Given this list of marker genes Slc19a2, Slc25a19, Slc19a3 (NCBI Gene Id 98426), Tpk1, Thtpa, here is a description of the gene set: Mouse Gene Set: REACTOME_VITAMIN_B1_THIAMIN_METABOLISM Vitamin B1 (thiamin) metabolism species: Mus musculus